Given this list of marker genes Lgals1, Zbtb7b, Hspb1 (NCBI Gene Id 15507), Il4, Fbxo7, Cd69, Sfrp1, Socs5, Nfkbid, Rc3h2, Lag3, Loxl3, Il2, Cd74, Bcl6, Tnfsf18, Gli3, Zc3h12a, Flt3, Tnfsf4, Erbb2, Runx3, Zfp608, Ifnb1, Cbfb, Irf1, Pglyrp3, Zfp35, Id2, Rag2, Dtx1, Runx1, Pglyrp2, Hmgb1, Hmgb3, Hlx, Pglyrp4, Nrarp, Clec4g, Smad7, Tmem131l, Pglyrp1, Prdx2, Ptpn2, Socs1, Foxp3, Zc3h8, Il4ra (interleukin 4 receptor, alpha), Slc4a2, Cdkn2a, Mdk, Rc3h1, Shh, Lilrb4b, Cd44, Anxa1, Bmp4, Tbx21, Ctla4, Foxj1, Ascl2, Fgl2, Ihh, Jak3, Lilrb4a, Pf4, here is a description of the gene set: Any process that stops, prevents, or reduces the frequency, rate or extent of lymphocyte differentiation. species: Mus musculus Mouse Gene Set: GOBP_NEGATIVE_REGULATION_OF_LYMPHOCYTE_DIFFERENTIATION